The following is a description of a gene set: Abnormality of pulmonary circulation studied in species Homo sapiens Human Gene Set: HP_ABNORMALITY_OF_PULMONARY_CIRCULATION A functional anomaly of that portion of the cardiosvascular system that carries deoxygenated blood from the heart to the lungs and returns oxygenated blood back to the heart., and this is the list of marker genes: IKBKG, MYH6 (myosin heavy chain 6), FGFR3, TNFSF11, SMAD9, KRAS, AGGF1, PIK3CA, GATA4, KIAA0319L, IL23R, UBAC2, MT-CO2, RPL3L, MT-CO3, DOCK6, MED12, LARS2, C4A, SOX9 (NCBI Gene Id 6662), FGFR1, EIF2AK4, PRDX1, NFU1, IL12B, ABCD4, ACVRL1, PIEZO1, ERI1, TNNT2, ADAMTSL2, MT-TS2, ARSB, KMT2D, CCR1, LIPT1, BMPR2, TBX5, PPCS, TNNI3, PLP1, CCN2, NDUFA8, PRIM1, SLC37A4, PIGA, CACNA1C, LMNA, GATA6, FBN1, SFTPC, AGR2, NKX2-5, KCNN4, TLR4, COL1A1, IL6ST, TERT, PROS1, COLQ, PIGN, MT-TW (NCBI Gene Id 4578), CCR6, COX8A, NKX2-1, PGM1, CTCF, MT-ND5, SERPINC1, MT-TQ, ZMPSTE24, CAPNS1, MYH11, KCNK3, FIG4, MT-ND6, KDM6A, MT-TF, MUC5B, MLX, STAT4, GNAQ, IL10, THPO, UBE2A (NCBI Gene Id 7319), IL6, LIFR, ATP5F1A, MT-ND4, MIF, CD55, TBX4, LACC1 (laccase domain containing 1), DEF6, ODAD1, HBB, GDF2, CITED2, EOGT, HLA-B, COX7B, VAC14, F13A1, NOTCH1, KIF20A, IL12A-AS1, MYBPC3, LAMB2, NOD2, NAA10 (N-alpha-acetyltransferase 10, NatA catalytic subunit), BTNL2, ALMS1, SFTPB, TRRAP, RHAG, ERAP1, DLK1 (NCBI Gene Id 8788), SMARCAL1, AKT1, MPL, JAK2, TCIRG1, ABCC6, PSMB9, THBD, IRF5, ENG, BANF1, KRT18, SNX10, MYMK, MYH7, ENPP1, CACNA1D, COG1, MT-TH, MEG3, ATP13A3, HSPG2, FOXF1, MMACHC, ACTA2, VPS33A, F8, G6PC3, AFF4, ACTC1, STAT1, F2, SARS2, VHL, TLL1, RTL1, NDUFB10 (NCBI Gene Id 4716), HLA-DRB1, ARHGAP31, COX6B1 (NCBI Gene Id 1340), CLCN7, IDUA (alpha-L-iduronidase, NCBI Gene Id 3425), MT-CO1, AGK, CLXN, COL1A2, VCL, CBS, ABCA3, DLL4, NF1, FBXL4, NFIX, SLC34A2, HABP2, PDSS1, ALDH1A2, PAM16, FAS, GBA1, TBX20 (T-box transcription factor 20), SFTPA2, ZNF699, MYPN, SMAD4, CAV1, FLNA, RBPJ, SLC25A24, LAMA2, FLNC, MED25 (mediator complex subunit 25), IPO8, PROC, EFEMP2, CA2, MGP, IFT56, IFNGR1, SCARB2, CHST3, FOXP1, MT-ND1, MTHFR, THSD1, COX5A, SLC4A1, KCNJ5, SLC29A3, KLRC4, MT-TL1, IL12A, MEFV